The following is a description of a gene set: from publication Chen Y, Wang X (PMID 31504780) species: Mus musculus Genes predicted to be targets of miRBase v22 microRNA mmu_miR_12187_5p in miRDB v6.0 with MirTarget v4 prediction scores > 80 (high confidence targets). Mouse Gene Set: MIR_12187_5P, and this is the list of marker genes: Nkapd1, Elavl2, Calm3, Cebpd, Dkk2, G3bp2, Golph3l, Bcl2l10 (NCBI Gene Id 97554), Gprc5b, Kdm4a, Larp4b, Gng2, Nav1, Rnf2, Ercc6l, Naaladl2, Amfr, Ppp1r17, Lgalsl, Wdr26, Slc39a2, Prox1, Usp2, Jrkl, Slc18a1, Fam169b, Zfp395, Icos, Kmt2a, Des, Zmym2, Arhgap24, Rab21, Tnfaip3, Pdlim5 (NCBI Gene Id 99766), Mtap, Blcap, Dnmt3b, Zc2hc1a, Saysd1, Ggcx, Mink1, Fzd8, Dpysl3, Arhgef9, Cnot9 (NCBI Gene Id 98400), Sox4, Negr1 (NCBI Gene Id 320840), Rapgef2, Mkrn3, Tube1, Kdm5c, Onecut2, Mnat1, Vit, Rfx3, Ywhaz, Gna14, Flrt2, Ash1l, Kcna5, Xndc1, Senp7, F13a1 (coagulation factor XIII, A1 subunit), Tfcp2, BC030500, Atp13a3 (NCBI Gene Id 385637), Akap7, Cplx4, Efnb1, Tectb, Ehf, Lrp8, Ncald, Slc38a5, Tpbg (NCBI Gene Id 264331), Zfp609, Fam120a, Septin6, Zic4, Zfp933, Dusp10, Slco3a1 (NCBI Gene Id 97427), Agap1, Prrt2, Creb3l2, Shoc2, Glb1l, Rimklb, Hus1, Tasl, Pdzd7, Krt90 (keratin 90), Csnk1e